Given this list of marker genes MGMT, SH3BGRL2, FAH, SYT7, CASP8 (NCBI Gene Id 841), GUCY1A1, RCN1, GJA10, CCR6, SYNC, SYNE4, SFR1, CDKN1C, F2R, PHLPP1, BUB1B (BUB1 mitotic checkpoint serine/threonine kinase B), STK19, HIF1A, TRIM59, ZNF467, MAPK10, PTCH1, TRIP6, BCAT1, TMEM158, RILPL2, TGM2, HACD3, HTRA2, EPCAM, FGFR3, SAMSN1, VPS54, VCP (NCBI Gene Id 94731), PCTP, CSPP1, SMARCD3, APOBEC1, GSTO1, DCAF4, VWA8, TNFRSF1B, BLTP3A, SMAP1, LIG1, GPLD1 (glycosylphosphatidylinositol specific phospholipase D1), IL1R2, IL2RB, CCDC28A, KCNA3, ZNF281, ADGRV1, XBP1, KRTCAP3, CAPN5, EPHX1, SLC22A2, KLHDC3, ECM1, DYNLT3, ATF4, CERK, CHGB, SMC4, PENK, ORC6, ABHD17C, HSD3B7, TMEM165, DYNLL2, PAICS, CNTROB, TARS2, FAM89A, SAR1A, HGFAC, ICOS, PDZK1IP1, OTUB1, KDM3B, MAOA, CA12, ACSBG1, REM2, CNMD, SCN11A (sodium voltage-gated channel alpha subunit 11), NR1D1, ANP32A, STX1A, PPIG, HBA2, C9, SOCS3, RBM3, DLX2, SDF4, ADAM8, GCAT, RGS10, GABARAPL1, PSMA3, SESN1, GBP7, KHDC1L, EIF3C, TMEM258, NCAPD2 (NCBI Gene Id 9918), BSPRY, ASNS, XDH, CCT5, CCDC25, GZMB, ZCCHC18 (zinc finger CCHC-type containing 18), CORO2A, SH3BGRL, WDR6, UPP1, PBX4, PIM1, ABCC1, RRAGD, HBS1L (HBS1 like translational GTPase), PLCB4, TWSG1, ZFYVE19, RECK, WLS, TTC39B, PLCB3, RSPH3, TNFRSF4, CYFIP1 (cytoplasmic FMR1 interacting protein 1), IL12RB1, SYTL2, UPF3B, ARL6IP1, CBX6, NUP62, SLC66A3 (NCBI Gene Id 130814), SLC35F6 (solute carrier family 35 member F6), RAB8B, MDN1, CEP89, TMEM87A, PRG4, HNRNPDL, TNNT2, SLC12A8, LRRC61, HNRNPC, POLK, TTI1, HEMK1, GNB5, VILL, ATP5F1C, DND1, DRC1, IL10RA, NCF4, DHRS3 (NCBI Gene Id 9249), SLC9B2 (solute carrier family 9 member B2), FGB, RAD51B, OCSTAMP (osteoclast stimulatory transmembrane protein), SLA, MTX1, NCR1, GALM, LAD1, TBC1D10A (TBC1 domain family member 10A), CPPED1, RAPSN, MCM5, ARHGAP20, MATN2, FAM118A, GFI1, HHIP, CCDC137, DNPH1, MBD1, PARD6G, PDCD1LG2, NUP88, CD70, BCL2, ARHGEF12, BCKDHB, CDK6, RASIP1, RGS16, TLR1, PCDH20, GPX7, ADPRH, EZH2 (NCBI Gene Id 392834), H1-0, CFAP157, here is a description of the gene set: from publication Layland LE, Mages J, Loddenkemper C, Hoerauf A, Wagner H, Lang R, da Costa CU (PMID 20007528) Genes up-regulated in comparison of regulatory T cell (Treg) from uninfected mice versus T effector cells from uninfected mice. Human Gene Set: GSE17580_TREG_VS_TEFF_UP Although several markers have been associated with the characterization of regulatory T cells (Treg) and their function, no studies have investigated the dynamics of their phenotype during infection. Since the necessity of Treg to control immunopathology has been demonstrated, we used the chronic helminth infection model S. mansoni to address the impact on the Treg gene repertoire. Before gene expression profiling we first chose to study the localization and antigen-specific suppressive nature of classically defined Treg during infection. Presence of Foxp3+ cells were found especially in the periphery of granulomas and isolated CD4+CD25hiFoxp3+ Treg from infected mice blocked IFN-gamma and IL-10 cytokine secretion from infected CD4+CD25- effector T cells (Teff). Furthermore the gene expression patterns of Treg and Teff showed that in total genes were significantly regulated during chronic schistosomiasis. Upon k-means clustering we identified genes exclusively regulated in all four populations including Foxp3, CD103, GITR, OX40 and CTLA-4: classical Treg markers. During infection however, several non-classical genes were up-regulated solely within the Treg population such as Slpi, Gzmb, Mt1, Fabp5, Nfil3, Socs2, Gpr177 and Klrg1. Using RT-PCR we confirmed aspects of the microarray data and in addition showed that the expression profile of Treg from S. mansoni-infected mice is simultaneously unique and comparative with Treg derived from other infections species: Homo sapiens